Given this list of marker genes COQ6, COQ7, PDSS2, COQ8A, STARD7, COQ9, COQ5, COQ3, COQ8B, COQ2, PDSS1, COQ4, HPDL, here is a description of the gene set: The length of the polyisoprenoid chain of ubiquinone, aka coenzyme Q (CoQ), varies depending on the species involved: it is 6 in budding yeast, Saccharomyces cerevisiae, (CoQ6) and 10 in humans (CoQ10). Most ubiquinone is naturally reduced to ubiquinol (CoQ10H2 in humans), and this form dominates in human tissues. It functions as a ubiquitous coenzyme in redox reactions, and has a central role in the electron transport chain of the inner mitochondrial membrane.to shuttle electrons from complexes I and II to complex III. It also acts as a cofactor for biosynthetic and catabolic reactions, detoxifies damaging lipid species, and engages in cellular signaling and oxygen sensing. In eukaryotes, ubiquinones/ubiquinols are also found in other membranes such as the endoplasmic reticulum, Golgi vesicles, lysosomes, peroxisomes and the plasma membrane.<br><br>Ubiquinol/ubiquinone is synthesized in the following way. Initially, mitochondrial 4-hydroxyphenylpyruvate dioxygenase-like protein (HPDL) processes 4-hydroxphenylpyruvate (HPP, HPPA) to (S)-4-hydroxymandelate (4-HMA). HPDL defects lead to CoQ10 deficiency. The HPDL product 4-HMA is a precursor for the synthesis of 4-hydroxybenzoate (PHB), from which the CoQ10 head group is derived. Because HPDL is a mitochondrial protein, cytosolic HPP from tyrosine catabolism must either be imported by a yet unknown transport mechanism or mitochondrial HPP could be the product of an unknown mitochondrial reaction. A polyprenyl diphosphate synthase (PDSS1-2) assembles the polyisoprenoid tail. Next, 4-hydroxybenzoate polyprenyltransferase (COQ2) catalyzes the formation of the covalent linkage between PHB and the polyisoprenoid tail to produce 4-hydroxy-3-polyprenyl benzoic acid intermediate (DHB, 3-decaprenyl-4-hydroxybenzoic acid in humans). Modifications of the aromatic ring follow and involve an oxidative decarboxylation, two hydroxylations, two O-methylations, one C-methylation. This series of reactions, which precise order is not fully established, especially regarding the oxidative decarboxylation step, yield the fully substituted hydroquinone, ubiquinol.<br><br><br>Homologs of the core enzymes COQ3, COQ4, COQ5, COQ6, COQ7, and COQ9 have been shown to form a membrane-localized multienzyme complex ("COQ synthome") in yeast. There is some evidence of such a complex, called complex Q, in humans. A complex was reconstituted in vitro with ancestral versions of COQ3-7 and COQ9, and was able to convert a short chain analog of DHB (4-Hydroxy-3-(3-methylbut-2-en-1-yl)benzoic acid) into CoQ1. COQ8A and COQ8B proteins may contribute to the formation and functionality of this complex, as they can bind to most core enzymes, and as COQ8B increased the in vitro activity of COQ6 via phosphorylation of COQ3..<br><br>Parts of CoQ10 synthesis may also occur in the Golgi and endoplasmic reticulum membranes, adding to the cellular membrane CoQ10 pool. The relevance of such processes seems minor.The precise function of two other genes, COQ10A and COQ10B, which appear to be quinone-binding proteins, is still under investigation. Most of the time, CoQ10 is transported out of the mitochondrion and to the plasma membrane by isoforms of the STARD7 lipid carrier.<br><br>CoQ10 deficiency, which can result from reduced activity of any biosynthesis core enzymes or the COQ8A, and COQ8B proteins, has significant implications. It is associated with several inherited metabolic disorders, the phenotypes of which are extremely heterogeneous. These disorders range from fatal neonatal presentations with multisystem involvement to adult-onset isolated myopathy. However, in many cases, the symptoms can be ameliorated by nutritional supplementation with CoQ10. part of: Metabolism of cofactors species: Homo sapiens Reactome Pathway: Ubiquinol biosynthesis